The following is a description of a gene set: species: Mus musculus Mouse Gene Set: GOBP_CELLULAR_RESPONSE_TO_ETHANOL Any process that results in a change in state or activity of a cell (in terms of movement, secretion, enzyme production, gene expression, etc.) as a result of an ethanol stimulus., and this is the list of marker genes: Mir30a, Mir152, Ncam1, Glra3, Mir362, Mir29c, Mir9-1, Slc23a2, Mir30e, Glra2, Dnmt3a, Trp53inp1, Pten, Rps6, Ugt1a1, Drd2, Cybb, Itpr2, Sod2, Ccl7, Mir200a (NCBI Gene Id 387242), Mir10b, Mir296, Mir10a, Hoxa1, Mir339, Glra1, Rps6-ps4, Kcnmb1, Adcy7, Mir496a, Prkce, Mir154, Mir9-2 (microRNA 9-2), Mir9-3, Prkaa1, Mir145a